The following is a description of a gene set: The process of directing proteins towards the peroxisome, usually using signals contained within the protein. Mouse Gene Set: GOBP_PROTEIN_TARGETING_TO_PEROXISOME species: Mus musculus, and this is the list of marker genes: Pex1, Pex6, Pex19, Pex16, Pex5, Hacl1, Lonp2, Pex7, Zfand6